The following is a description of a gene set: studied in species Mus musculus Mouse Gene Set: MIR_1843A_5P Genes predicted to be targets of miRBase v22 microRNA mmu_miR_1843a_5p in miRDB v6.0 with MirTarget v4 prediction scores > 80 (high confidence targets). from publication Chen Y, Wang X (PMID 31504780), and this is the list of marker genes: Banf1, Sh3rf1, Cdc27, Trim41, Itga4, Tnrc6a, Fxr1, Zfp91, Capn6, Nmur2, Slc35c1, 2310022B05Rik, Acot9, Hecw1, Alkbh7, Atp6v0e, Scamp1, Ms4a4c, Tcp10c, Necap1 (NCBI Gene Id 67602), Clvs1, Dnajc7, Ugt2b35, Hfe, Mbd6, Kdm5d, Capzb, Purg, Cyp2g1, Adam25, Ralgapa2, Man1a2, Kmt5b, Stox2, Micall1, Uap1, Gstm2, Zfp39, Ctnnd1, Card10, Ints4, Trappc9, Tmem167, Scaf8, Myo18a (NCBI Gene Id 360013), Sbk3, Zbtb16, Slc38a3, Mbnl3